The following is a description of a gene set: Mouse Gene Set: CUI_T_CELL_CD4_GDNF_RESPONSE_DN from publication Cui A, Huang T, Li S, Ma A, Pérez JL, Sander C, Keskin DB, Wu CJ, Fraenkel E, Hacohen N (PMID 38057668) species: Mus musculus Cytokines mediate cell-cell communication in the immune system and represent important therapeutic targets. A myriad of studies have highlighted their central role in immune function, yet we lack a global view of the cellular responses of each immune cell type to each cytokine. To address this gap, the authors created the Immune Dictionary, a compendium of single-cell transcriptomic profiles of more than 17 immune cell types in response to each of 86 cytokines (>1,400 cytokine-cell type combinations) in mouse lymph nodes in vivo. A cytokine-centric view of the dictionary revealed that most cytokines induce highly cell-type-specific responses. For example, the inflammatory cytokine interleukin-1β induces distinct gene programmes in almost every cell type. A cell-type-centric view of the dictionary identified more than 66 cytokine-driven cellular polarization states across immune cell types, including previously uncharacterized states such as an interleukin-18-induced polyfunctional natural killer cell state. Genes negatively differentially expressed in cell type: CD4+ T cell upon treatment with cytokine: GDNF in mouse lymph nodes in vivo., and this is the list of marker genes: Tsc22d3, H2-Aa, Hspa1b, Hspa1a, H2-Eb1, Cd74